The following is a description of a gene set: from publication Johnson K, Hashimshony T, Sawai CM, Pongubala JM, Skok JA, Aifantis I, Singh H (PMID 18280186) Human Gene Set: GSE10273_HIGH_IL7_VS_HIGH_IL7_AND_IRF4_IN_IRF4_8_NULL_PRE_BCELL_UP Genes up-regulated in IRF4 and IRF8 null pre-B cell treated with 5ng/ml IL7 versus those transduced with IRF4. Productive rearrangement of the immunoglobulin heavy chain locus triggers a major developmental checkpoint that promotes limited clonal expansion of pre-B cells, culminating in cell cycle arrest and rearrangement of the kappa (κ) or lambda (λ) light-chain loci. B lineage cells lacking the related transcription factors IRF-4 and IRF-8 undergo a developmental arrest at the cycling pre-B cell stage and are blocked for light-chain recombination. Using Irf-4,8-/- pre-B cells we demonstrate that two pathways converge to synergistically drive light-chain rearrangement, a process that is not simply activated by cell cycle exit. One pathway is directly dependent on IRF-4, whose expression is elevated by pre-BCR signaling. IRF-4 targets the κ 3′ and λ enhancers to increase locus accessibility and positions a kappa allele away from pericentromeric heterochromatin. The other pathway is triggered by attenuation of IL-7 signaling and results in activation of the κ intronic enhancer via binding of the transcription factor, E2A. Intriguingly, IRF-4 regulates the expression of CXCR4 and promotes the migration of pre-B cells in response to the chemokine CXCL12. We propose that IRF-4 coordinates the two pathways regulating light-chain recombination by positioning pre-B cells away from IL-7 expressing stromal cells. We used microarrys to identify the changes in gene expression under different levels of the cytokine IL-7 and after rescue of genetic defect. studied in species Homo sapiens, and this is the list of marker genes: HOXA7, CTPS1, CSE1L, NUP42, PRKG1, NUP107, C7orf50 (NCBI Gene Id 84310), ANKLE1, BMAL1, HEATR5A, PARD3, CDC45, HSPBP1, IBA57, CEL, BUD13, PCBP3, TRIM47, FAM167A, SHH, KCNMA1, KIF17, GTF2H2, RAD18, KNOP1, OTUD6B, ADM, SRFBP1, BMP6, TGIF2, UCP2, ATAD5, SPACA3 (NCBI Gene Id 94024), FAM110A, ISCU, MMP11, TMEM39A, P3H3, HNRNPH1, ADAMTS3, SRRT, TPD52, ZFP36, SLC7A5, CSAD (NCBI Gene Id 51380), UROS, SLC25A1, ANKRD37, PDE6D, PRKCI, CPSF2, REN, SMO, SLC2A5, NME7, ELAC2, SPATA6, TTC4, CHCHD4, ISOC1, PRELID3A, JUN, RFC2, TBXA2R, SCT, DIAPH3, MAOA, PCK2, AGPAT5, PAIP1, NRF1, TENT4A, VPS18, TAPT1, CENPS, GOT1L1, CDKN3 (cyclin dependent kinase inhibitor 3), DQX1, P2RX4, HDGF, AOX1 (aldehyde oxidase 1), TMEM183A, THBS2, GEMIN6, NDUFAF4, LGR5, NMRAL1, JADE3, ELF3, N4BP2, CFAP298, PLA2G1B, MIIP, CDKN2A, ADSL, GALNT14, PRR11 (proline rich 11), ERG, CNIH1, OR51E1, P2RX2, ACVR1C, HIRIP3, THOP1, CLEC10A, FAM170B, GSTCD, SDC4, SHROOM3, CHAF1B, CCNF, FGFRL1 (NCBI Gene Id 54966), KIAA0930, PPP2CB, BANF1, CCP110, TCF3, ASAH2, SYDE2, CDCA5, PRPF4, PLK2, E2F1, GSTO1, TTF2, NOLC1, AHI1, CD5, STOML2, SYNGR1, HMGN5, TEX30, RNMT, MIPEP, SBSN, DHX33, TMEM98, NUP93, FASTKD3, BDH1, KHDRBS3, SLC15A3, GSTT2, CNN1, RGCC, GALNT9, LRRC8D, GJA10, EIF4A3, B3GNT2, CSTPP1, SOBP (NCBI Gene Id 654119), ZC3HC1, TIMM9, EIF2B3, MLH1, PRC1, FBXW12, PGGHG, ADI1, RPS6KC1, HIBCH, NEK2, GINS1, SMARCA5 (SWI/SNF related, matrix associated, actin dependent regulator of chromatin, subfamily a, member 5), FZD6, SLC43A3, GFM1, THYN1, BRCA2, NDUFA9, SMTN, APOBEC3B, CDKN1A, ERLIN1, SREK1IP1, DNLZ, SPI1, DDX3X, IFITM3, KLRC2, DBF4, TPRN, PTGS1, CRTAP, BARD1, LRRC49, SAP30, LMO3, INTS7, TMA16, IFT22, DDX47, TF, SPATA24, C11orf24, PCK1, PSMD1, ARL2, GTF2F2